The following is a description of a gene set: studied in species Homo sapiens from publication Chen Y, Wang X (PMID 31504780) Genes predicted to be targets of miRBase v22 microRNA hsa-miR-4425 in miRDB v6.0 with MirTarget v4 prediction scores > 80 (high confidence targets). Human Gene Set: MIR4425, and this is the list of marker genes: SERPINF2, CENPV, CDV3, TPO, POLR3B, FOXA1, FOXA2, TP53RK, ARHGAP44 (Rho GTPase activating protein 44), DR1, PRDM1, ARB2A, CHD1, EPPIN, KCND1, RAB3B, NAPG, PEG3, ADAMTS5, DTX4, ATAT1, PPM1D, ERVV-1, TMEM39B, PCDH7, PEAK1, GABRB3, SH3D19, HIVEP3, RNASE9 (ribonuclease A family member 9 (inactive)), UST, IL13RA1, IPO13, CNP, URI1, MARVELD3, RB1CC1, PDZD2, CXXC4, NOL6, MEX3C, PHAX, MUC7 (NCBI Gene Id 93297), KCNH4, ATP2B1, CKAP2L, UBE2Z, FNDC3A, DENND6A, NSD1, CXADR, CCDC92, PRR3, STAU1, VWA5A, SH2D1B, NFASC, RRM2B, SRP19, SLC36A3, MACF1, CYP4X1, PUM2, KCTD18, CTPS2, TRPS1, CHST9, MREG, SECISBP2L (SECIS binding protein 2 like), TMEM14B (NCBI Gene Id 81853), DCTN5, CHMP1B, SLC25A12, SNX19, STXBP5L, CFAP44, WDR33, ATP8A2, CCNT1, PALM2AKAP2, MYO5A, RASAL2, STC1, SCG2, PLEKHS1, HAPLN1, VPS13A, MYEF2, BSDC1